Given this list of marker genes Klf4, Vim, Hspa8, Tsc22d3, Uba52, here is a description of the gene set: studied in species Mus musculus from publication Cui A, Huang T, Li S, Ma A, Pérez JL, Sander C, Keskin DB, Wu CJ, Fraenkel E, Hacohen N (PMID 38057668) Mouse Gene Set: CUI_CDC1_IL11_RESPONSE_DN Genes negatively differentially expressed in cell type: cDC1 (conventional dendritic cell type 1) upon treatment with cytokine: IL-11 in mouse lymph nodes in vivo. Cytokines mediate cell-cell communication in the immune system and represent important therapeutic targets. A myriad of studies have highlighted their central role in immune function, yet we lack a global view of the cellular responses of each immune cell type to each cytokine. To address this gap, the authors created the Immune Dictionary, a compendium of single-cell transcriptomic profiles of more than 17 immune cell types in response to each of 86 cytokines (>1,400 cytokine-cell type combinations) in mouse lymph nodes in vivo. A cytokine-centric view of the dictionary revealed that most cytokines induce highly cell-type-specific responses. For example, the inflammatory cytokine interleukin-1β induces distinct gene programmes in almost every cell type. A cell-type-centric view of the dictionary identified more than 66 cytokine-driven cellular polarization states across immune cell types, including previously uncharacterized states such as an interleukin-18-induced polyfunctional natural killer cell state.